The following is a description of a gene set: Systems biology is an approach to comprehensively study complex interactions within a biological system. Most published systems vaccinology studies have utilized whole blood or peripheral blood mononuclear cells (PBMC) to monitor the immune response after vaccination. Because human blood is comprised of multiple hematopoietic cell types, the potential for masking responses of under-represented cell populations is increased when analyzing whole blood or PBMC. To investigate the contribution of individual cell types to the immune response after vaccination, we established a rapid and efficient method to purify human T and B cells, natural killer (NK) cells, myeloid dendritic cells (mDC), monocytes, and neutrophils from fresh venous blood. Purified cells were fractionated and processed in a single day. RNA-Seq and quantitative shotgun proteomics were performed to determine expression profiles for each cell type prior to and after inactivated seasonal influenza vaccination. Our results show that transcriptomic and proteomic profiles generated from purified immune cells differ significantly from PBMC. Differential expression analysis for each immune cell type also shows unique transcriptomic and proteomic expression profiles as well as changing biological networks at early time points after vaccination. This cell type-specific information provides a more comprehensive approach to monitor vaccine responses. from publication Hoek KL, Samir P, Howard LM, Niu X, Prasad N, Galassie A, Liu Q, Allos TM, Floyd KA, Guo Y, Shyr Y, Levy SE, Joyce S, Edwards KM, Link AJ (PMID 25706537) Genes down-regulated in natural killer cell 7d vs 0d in adults after exposure to 2011-2012 trivalent inactivated vaccine (A/California/7/09 (H1N1), A/Perth /16/2009 (H3N2), B/Brisbane/60/2008), time point 7D. Comment: Down-regulated DE RNA transcripts (down >= 1.5x) shared between both TIV-vaccinated donors studied in species Homo sapiens Human Gene Set: HOEK_NK_CELL_2011_2012_TIV_7D_VS_0DY_ADULT_7D_DN, and this is the list of marker genes: KIF15, FOSB, MCM10, PNMT, DTL, JUN (NCBI Gene Id 3725), GINS2, OAF, RAD51, GOLGA8R, RAD54L, RNU1-1, CFAP68, MORN1, CDC45, PKMYT1, PODXL, ODC1-DT (NCBI Gene Id 102723993), AVPR2